The following is a description of a gene set: Mouse Gene Set: chrYC1 species: Mus musculus, and this is the list of marker genes: Gm21256, Gm20889, Gm21387, Gm29267, Gm28234, Gm20802, Gm29319, Gm28697, Gm28194, Gm29321, Gm21271, Gm28871, Gm29647 (NCBI Gene Id 102640051), Gm21275, Gm29370, Gm21751, Gm29268, Gm21209, Gm21117, Gm29098 (NCBI Gene Id 102633876), Gm29166 (NCBI Gene Id 102634937), Gm20887, Gm28603, Gm28091, Gm29248, Gm29320, Gm21396, Gm29249, Gm21249, Gm28908, Gm20920, Gm21308, Gm21191, Gm28736, Gm21902, Gm20747, Gm21316, Gm29212, Gm21749, Gm28326, Gm20923, Gm21906, Gm28554, Gm28314, Gm21302, Gm29213, Gm29120, Gm28682, Gm20883, Gm20880, Gm20884, Gm28944, Gm28291, Gm28459, Gm21285, Gm28461, Gm21258, Gm20792, Gm21170, Gm28907, Gm21849, Gm28193, Gm28553, Gm28738, Gm21268, Gm28753 (NCBI Gene Id 102637651), Gm29121, Gm21779, Gm21740, Gm28290, Gm28943, Gm29073, Gm21245, Gm21247, Gm21281, Gm28851, Gm20929, Gm28604, Gm29169, Gm20881, Gm29211, Gm28683, Gm28870, Gm21899